Given this list of marker genes PSMD13, PSMD1, CHEK1, RPS27A, SKP1, PSMA7, PSMB7 (NCBI Gene Id 5695), BTRC, PSMA6, PSMD14, PSMD6, MAPK14, PSMB4, FBXW11, PSMA4, PSMA3, CSNK1E, PSMD12, PSMD7, PSMC1, UBC, PSMA5, PSMB2, PSMB3, PSMD8, PSMD2, UBA52, PSMB1, PSMC2, PLK3, UBB, PSMB6, MAPK11, PSMC3, PSMC5, PSMA1, SEM1, PSMD11, CDC25A, RBX1, NEK11, PSMA2, PSMB5, PSMC4, CHEK2, PSMC6, CSNK1A1, CUL1, PSMD3, GSK3B (NCBI Gene Id 2932), ADRM1, here is a description of the gene set: <p>CDC25A protein, a phosphatase required for progression from G1 to S phase of the cell cycle, is degraded by the ubiquitin-proteasome machinery in both terminally differentiating and cycling cells.</p><p>In response to UV light or ionizing radiation (IR), CDC25A in human cells undergoes a rapid ubiquitin- and proteasome-dependent degradation that depends on CHEK1 but not TP53, inducing G1/S arrest that can be bypassed by overexpression of CDC25A. CHEK2 (Chk2) contributes to CDC25A destruction in response to IR. For details, please refer to events "Phosphorylation of CDC25A by CHEK1", "Phosphorylation of CDC25A by CHEK2", and "CHEK1 phosphorylates CHEK2-phosphorylated CDC25A". Treatment with hydroxyurea, which induces DNA replication stress and can indirectly lead to DNA damage, leads to a marked decrease in CDC25A protein levels in many human cell lines in a ubiquitin- and proteasome-dependent manner and persistent phosphorylation of CDK2 on tyrosine residue Y15. Besides CHEK1 and CHEK2, other kinases that may contribute to phosphorylation of CDC25A that targets it for ubiquitin-mediated degradation in response to DNA damage or replicative stress are PLK3 and GSK3B. Osmotic stress can also lead to p38 MAPK phosphorylation-dependent ubiquitination and degradation of CDC25A. Phosphorylation of CDC25A by CHEK1 and likely p38 MAPK and GSK3B primes it for additional phosphorylation by kinases such as NEK11 or Casein kinases I, which creates a phosphodegron needed for binding to the SCF-BTrCP E3 ubiquitin ligase complex, leading to ubiquitin-mediated degradation of CDC25A.</p> studied in species Homo sapiens Reactome Pathway: Ubiquitin-Mediated Degradation of Phosphorylated Cdc25A part of: p53-Independent G1/S DNA Damage Checkpoint